The following is a description of a gene set: Human Gene Set: GSE3982_MAST_CELL_VS_MAC_DN from publication Jeffrey KL, Brummer T, Rolph MS, Liu SM, Callejas NA, Grumont RJ, Gillieron C, Mackay F, Grey S, Camps M, Rommel C, Gerondakis SD, Mackay CR (PMID 16474395) studied in species Homo sapiens Genes down-regulated in comparison of mast cells versus macrophages. In the present study we used Affymetrix oligonucleotide microarrays to produce gene transcription profiles for the major leukocyte types in humans. This comprehensive dataset enabled us to not only establish which genes were expressed in each leukocyte type, but also which genes were expressed in each subset after activation. The used of a comprehensive dataset of gene profiles from all the major human leukocyte subsets enabled a novel and powerful means for identification of genes associated with single leukocyte subsets, or different immune paradigms., and this is the list of marker genes: GPT, SNX5, STX2, EPB41L3, CTNNA1, CAPZA2, LTBR, UCHL1, GABARAPL3, MKLN1, NR6A1, HLX, SP3P, TREM2, FDX1, ALCAM, TMED5, ERO1B (NCBI Gene Id 56605), USP12, JUN (Jun proto-oncogene, AP-1 transcription factor subunit), CSPG4, IMPDH1, MITF, MAN2B1, PHACTR2, ETHE1, ARMCX1 (NCBI Gene Id 51309), IL13RA1, UCHL3, FABP4, RAC1, ZNF706, GUSB, TPK1, SERPINB8, TMEM140, SCPEP1, MRTFB, VWA8, RBL1, TNFSF14, MFSD1, H2AC16, ITGA3, PDXK, LRP1, STAT1, CYFIP1, H4C2, FKBP5, SLC7A8, FCHSD2, PLS3, DAB2, PSMD12, TNFRSF1A, L2HGDH, PPP2R3A, RXRA, NSF, DDO, NANS, RAI14, SIRT2, CREBL2 (NCBI Gene Id 1389), PTMS, SLC6A12, SLBP, CNIH3, MANEA, SPAG9, ADK, MCM5, QSER1, DDX52, RHEB, ELOC, KPNA2, ME1, FOXO3, RABGGTB, MPZL1, MED1, CXCL5, TEX2, RAB8B, ENG, GTF2IRD1, PPT1 (palmitoyl-protein thioesterase 1), TUBB6, PLEK2, RAB17, RMDN3, NEU3, DNASE2B, PSMA6, MXI1, MTF1, FLNA, IQCG, ACP2, INHBA, AOX1, ADH5, CLPTM1, OPTN, KLHDC3, TMEM134, ACOX1, CLIP4, ASPHD1, EEF1AKMT3, TRIM25, RAB36, GABBR2, TNFRSF12A, MPZL2, HEXA, TGFBR1, HMGB3P30, AP2B1, GALNS, KIF2A, FAM200C, ATP2B2, NFAT5, UBAP1, INF2, ARMT1, ADAM9, WAPL, NCSTN, HMCES, GIMAP5, IL10RA, KMO, DOCK3, KCNJ1, SCARF1, EPAS1, AK4, CD47, IFNA1, S100A10, SNX13, ATN1 (NCBI Gene Id 1822), RPP25, DEF8, CDK16, DNAJB14, JCHAIN, ATP1A1 (NCBI Gene Id 476), RPS6KB1, GINS4, PRORP, GRAMD1B, PPARD, RHOQ, PIK3C2G, EML4 (NCBI Gene Id 54548), CLEC2B, EIF5B, PILRA, BAG4 (BAG cochaperone 4), ADAP2, BLCAP, NAGPA, PCOLCE2, IL27RA, RC3H2, ZNF804A, RP2, HIVEP3, ITGAM, GLRX2, CTSS, ZDHHC7, INSM1, CLCN7, CELSR1, PARP8, RNASE6, MATK, CD36, CCR5, MARCHF1, GGA2, GNL1, TRPV6, SRSF11, EPCAM, GASK1B, RNF40, ADGRE3, BCL2L1